Given this list of marker genes Akt1, Agtr1b, Nr4a1 (NCBI Gene Id 15370), Col18a1, Saal1, Htra1, Cdh3, Mydgf, Ccr3, Egf, Hmga2, Vip, Gpbar1, Cyba, Ccl11, Sema5a (NCBI Gene Id 320921), Foxe3, Vegfb, Prok1, Trp63, Nr4a3, Gata2, Ccl2, Igf2, Pold4, Ccl24, Sfrp1, Hras, Srsf6, C5ar1, Osr2, Sp1, Vegfa, Dlx5, Itpr1, Htr2b, Aggf1, Rptor, Nod2, Ang6, Prl, Fgf18, Foxp2, Ar, Dicer1, Pdx1 (NCBI Gene Id 18609), Odam, Il6, Zfp703, Gdf2, Cav2, Wdr48, Ccl26, Nras, Prkca, Hpn, Erbb3, Wnt2, Stat3, Epgn, Eya1, Sirt1, Esrp1, Ecm1, Sox9, Cdc25a, Notch2, Ccl5, Itga4, Pdcl3, Apela, Esrp2, Stat5a, Tbx1, Wnt5a, Twist2, Hmgb2, Ang5, Cxadr, Pik3cd, Plcg1, Bad, Vegfc, Hmx2, Bmp5, Nodal, Fgfbp1, Gli2, Med1, Grn, Fgfr1, Il18, Zfp580, Kdm5b, Nf1, Ccnd2, Irs2, Tgfb1, Phip (NCBI Gene Id 83946, pleckstrin homology domain interacting protein), Jaml, Cdk4, Dlx6 (NCBI Gene Id 13396), Tnfaip3, Vash2, Flt4, Prox1, Has2, Atp7a, Cyp7b1, Bmp4, Apln, Hdac6, Nkx2-5, Mycn, Yap1, Jun, Egfl7, Dab2ip, St8sia1, Azin1, Fgf2, Reg3a, B4galt1, Eppk1, Vhl, Tnf, Iqgap3, Akt3, Sox11, Plxnb3, Hlx, Nme1, Cdh13, Prkd1, Fzd7, Mmp12, Tgm1, Nog, F3, Ctnnb1, Ptn, Bmpr1a, Nrarp (NCBI Gene Id 67122), Wnt3a, Ihh, Osr1, Il10, Pdcd6, Sirt6, Rtn4, Hyal1 (hyaluronoglucosaminidase 1), Pgf, Cflar, Rbpj, Adam17, Kdr, Cldn1, Pdpk1, Erbb2, Smo, Crnn, Nkx2-6, Acvrl1, Bmyc, Hrh3, Map2k5, Cxcl12, Erbb4, Hmgb1, Fgf7 (fibroblast growth factor 7), Fgfr2, Shh, Pkhd1, Fgfr3, Ccnd1, Thbs4, Itgb3bp, Mta3, Agap2, Gas1, Fgf1, Egr3, Reg3g, Fgf10, Dysf, Mir205, Glul, Igf1, Ghrl, Extl3, Lrg1, Ang, Ang4, Twist1, Ang2, Stxbp4, Nme2, Rictor, Bnc1, Pax2, Agtr1a, Tcf7l2, Jcad, Pdgfb, Mst1, Tacr1, Tbx18, Mdk, Egfr, Aplnr, Bmp6, Arg1, Foxp1, Tgfa, Scn5a, Ghsr, Kif3a, Ppp1r16b, Reg1, Emc10, Runx2, Mtor, Ptprn, Fgf9 (NCBI Gene Id 252883), Cav1, Rreb1, Wnt7a, Xbp1, Cdc42 (NCBI Gene Id 12540), Prkd2, Adora2b, Notch1, Id1 (inhibitor of DNA binding 1, HLH protein), Itgb3, Esr1, Scg2, Btk, Tgfbr1, Myc, Hmox1, Hspg2, here is a description of the gene set: studied in species Mus musculus Any process that activates or increases the rate or extent of epithelial cell proliferation. Mouse Gene Set: GOBP_POSITIVE_REGULATION_OF_EPITHELIAL_CELL_PROLIFERATION